Given this list of marker genes GRHL1 (NCBI Gene Id 29841), AK3, INPP4A, ERF, RGL1, H2AC25, TAF15, PLCB1, XPO7, MAP2K6, TNS2, CALCRL, TUBA1A, GABARAPL2, RGS6, TSC22D3, IKZF2, MIR22HG, WDR47, DENND4A, JPH3, SH3GL2, TAGLN3, TSC22D1, RNF145, H2BC26, PTHLH, PRICKLE1, MREG, MED12L, IL34, ARID1B, EPN2, ATF3, SARNP, NEUROD6, TMEM185A (NCBI Gene Id 84548), ZDHHC14, CDK8, VEGFA, WDR81, HERPUD1, HRH3, MPP2, AHNAK, PDXP, NAA60, SPATA2, ZNF711, PPFIA1, FNBP1, CSNK1E, ZHX2, DGKI, HOXA10, PCK2, PRELID1, PREX2, NIPBL, SEC14L3 (SEC14 like lipid binding 3), SEL1L3, TBX6, FBXW4, OGT, FBXO3 (F-box protein 3), CALM2, NYX, ATOH7, TNFSF13, TFEB, PIK3R1, CLASP1, CDKL1, SAT1, FAIM2, PELI2, ADNP, UNC5C, PRDM8, TMEM215, PRKG1, RHOBTB2, FOXO3, DDX5, ELOVL6, NPTX1, CDYL, KDM6A, CRIM1, PCSK2, NMT2, IL1RAPL1, ZBTB21, NCKAP5 (NCBI Gene Id 401013), ZBTB14, KCNJ1, SREBF2, ALDH1A1, ELAVL4, DMD, MAP2K3, IFNG, ELMOD1, NECTIN1, ENSA, CHIC2, RPS6KA3, LAMP5, ZBTB7A, GPM6A, BSN, MECP2, CREB5, C1QTNF7, HOXC6, WEE1, CEPT1, MAP4, ATXN1, HSPE1, PMEPA1, NIN, SLC24A2, JMJD1C, ECM2, TMEM126B, RASL10B, FUT9, RAB24, YTHDF3, EEF2, IMPDH1, ANGPTL1, IRF2BP1, PNMA1, POGZ, STARD13, ARRDC3 (NCBI Gene Id 57561), TMC3, CLCN5, OLFM4, CIART, ORMDL2, AGO3, SCML4, HOXA4, ANO1, CEP95, LGALSL, SUMO1, TMCC1, LGSN, SIDT1, PDZD8, NDST3, PALS2, KRTAP19-5, RABL6, UCHL1, ACSL4, NRSN1, POLG2, SMAP2 (NCBI Gene Id 64744), RBFOX2, HSPD1, RAI2, PGK1, ETV4, PIP4K2B, AP1S2, USP2, NEGR1, OSBPL6, ETV5, NREP, LRP1B, ZNF687, ERGIC1, ABHD8, LINC00472, CNTF, RAB3C, ZDHHC5, PRKAA2, ESRRG, NFIL3, ENSG00000291228, MIOX, COL15A1, PRNP, HIVEP3, PALS1, NRGN, UBR5, EP300, FGF14, ARNT, EPHX4, LARGE1, CLSTN1, EPB41, RSKR, IL6ST, HOXC4, ADRB2, SRSF6, YWHAG, CALM1, CLCN1, H3-3A, MACO1, SYT11, SULF1, VGLL4, TMEM154, C22orf31, FBXW7, ALDH3A1, AKTIP (AKT interacting protein), NR1D1, DNAJA2, CDC42, SH2B3, here is a description of the gene set: Human Gene Set: E4BP4_01 studied in species Homo sapiens Genes having at least one occurrence of the motif NRTTAYGTAAYN in the regions spanning 4 kb centered on their transcription starting sites. This matches the NFIL3 transcription factor binding site V$E4BP4_01 (v7.4 TRANSFAC).